Given this list of marker genes PRKAA1, CD160, GSDME, CRTAM, HLA-DRB3, KLHL22, HSPD1, MR1, CD226, IL12A (NCBI Gene Id 3592), IL12B, NECTIN2, FBXO38, PVR (NCBI Gene Id 5817), SLC22A13 (NCBI Gene Id 9390), HLA-DRB1, YWHAG, HRG (NCBI Gene Id 3273), here is a description of the gene set: Any process that activates or increases the frequency, rate, or extent of a response to tumor cell. Human Gene Set: GOBP_POSITIVE_REGULATION_OF_RESPONSE_TO_TUMOR_CELL species: Homo sapiens